The following is a description of a gene set: Mouse Gene Set: REACTOME_CS_DS_DEGRADATION CS/DS degradation species: Mus musculus, and this is the list of marker genes: Cspg4, Dcn, Bcan, Ids, Arsb, Hexa, Hexb, Idua, Bgn, Hyal1, Vcan, Cspg5, Hyal3